Given this list of marker genes H3C1, KDM3A, KDM4B, KDM6B, UTY, KDM5C, KDM7A, KDM2A, H3C15, PHF8, KDM2B, KDM1A, JMJD6, ARID5B, RIOX2, H4C1, KDM4A, KDM5A, KDM5B, KDM3B, PHF2, KDM4D, KDM5D, KDM4C, KDM6A, KDM1B, here is a description of the gene set: Reactome Pathway: HDMs demethylate histones species: Homo sapiens part of: Chromatin modifying enzymes Histone lysine demethylases (KDMs) are able to reverse N-methylations of histones and probably other proteins. To date KDMs have been demonstrated to catalyse demethylation of N-epsilon methylated lysine residues. Biochemically there are two distinct groups of N-epsilon methylated lysine demethylases with different catalytic mechanisms, both of which result in methyl group oxidation to produce formaldhyde. KDM1A, formerly known as Lysine Specific Demethylase 1 (LSD1), belongs to the flavin adenine dinucleotide (FAD)-dependent amino oxidase family. The KDM1A reaction mechanism requires a protonatable lysine epsilon-amine group, not available in trimethylated lysines, which consequently are not KDM1 substrates. Other KDMs belong to the Jumonji C (JmjC) -domain containing family. These are members of the Cupin superfamily of mononuclear Fe (II)-dependent oxygenases, which are characterised by the presence of a double-stranded beta-helix core fold. They require 2-oxoglutarate (2OG) and molecular oxygen as co-substrates, producing, in addition to formaldehyde, succinate and carbon dioxide. Histone literature typically refers to coordinates of the protein after the initiating methionine has been removed. In contrast, lysine-10 (H3K9) promoter methylation is considered a repressive mark for euchromatic genes and is also one of the landmark modifications associated with heterochromatin.<br>The first reported JmjC-containing demethylases were KDM2A/B (JHDM1A/B, FBXL11/10). These catalyse demethylation of histone H3 lysine-37 when mono- or di-methylated (H3K36Me1/2). They were found to contain a JmjC catalytic domain, previously implicated in chromatin-dependent functions (Clissold & Ponting 2001). Subsequently, many other JmjC enzymes have been identified and discovered to have lysine demethylase activities with distinct methylation site and state specificities. <br>KDM3A/B (JHDM2A/B) are specific for mono or di-methylated lysine-10 on histone H3 (H3K9Me1/2). KDM4A-C (JMJD2A-C/JHDM3A-C) catalyse demethylation of di- or tri-methylated histone H3 at lysine-10 (H3K9Me2/3), with a strong preference for Me3. KDM4D (JMJD2D) also catalyses demethylation of H3K9Me2/3. KDM4A-C (JHDM3A-C) can also catalyse demethylation of lysine-37 of histone H3 (H3K36Me2/3). KDM5A-D (JARID1A-D) catalyses demethylation of di- or tri-methylated lysine-5 of histone H3 (H3K4Me2/3). KDM6A and KDM6B (UTX/JMJD3) catalyse demethylation of di- or tri-methylated lysine-28 of histone H3 (H3K27Me2/3).<br><br>KDM7A (KIAA1718/JHDM1D) catalyses demethylation of mono- or di-methylated lysine-10 of histone H3 (H3K9Me1/2) and mono- and di-methylated lysine-28 of histone H3 (H3K27Me1/2). PHF8 (JHDM1E) catalyses demethylation of mono- or di-methylated lysine-10 of histone H3 (H3K9Me1/2) and mono-methylated lysine-21 of histone H4 (H4K20Me1). PHF2 (JHDM1E) catalyses demethylation of mono- or di-methylated lysine-10 of histone H3 (H3K9Me1/2). JMJD6 was initially characterized as an arginine demethylase that catalyses demethylation of mono or di methylated arginine 3 of histone H3 (H3R2Me1/2) and arginine 4 of histone H4 (H4R3Me1/2) although it was subsequently also characterized as a lysine hydroxylase. N.B. Histone literature typically refers to coordinates of the protein after the initiating methionine has been removed.